The following is a description of a gene set: studied in species Homo sapiens Human Gene Set: GOBP_VITAMIN_D_RECEPTOR_SIGNALING_PATHWAY A nuclear receptor-mediated signaling pathway initiated by vitamin D binding to an intracellular receptor of the nuclear receptor protein family, and ending with regulation of a downstream cellular process, e.g. transcription., and this is the list of marker genes: TRIM24, MED1, GPRIN3, MN1, SNW1, CYP27B1, RXRA, SNAI2, KANK2, CYP24A1, VDR, NCOA3, RXRB, PIM1